Given this list of marker genes AQP10, AQP2, AQP6, AQP5, AQP12A, AQP1, AQP8, MIP, AQP9, AQP4, AQP7, AQP11, AQP3, here is a description of the gene set: Reactome Pathway: Passive transport by Aquaporins Aquaporins (AQP's) are six-pass transmembrane proteins that form channels in membranes. Each monomer contains a central channel formed in part by two asparagine-proline-alanine motifs (NPA boxes) that confer selectivity for water and/or solutes. The monomers assemble into tetramers. During passive transport by Aquaporins most aquaporins (i.e. AQP0/MIP, AQP1, AQP2, AQP3, AQP4, AQP5, AQP7, AQP8, AQP9, AQP10) transport water into and out of cells according to the osmotic gradient across the membrane. Four aquaporins (the aquaglyceroporins AQP3, AQP7, AQP9, AQP10) conduct glycerol, three aquaporins (AQP7, AQP9, AQP10) conduct urea, and one aquaporin (AQP6) conducts anions, especially nitrate. AQP8 also conducts ammonia in addition to water.<br>AQP11 and AQP12, classified as group III aquaporins, were identified as a result of the genome sequencing project and are characterized by having variations in the first NPA box when compared to more traditional aquaporins. Additionally, a conserved cysteine residue is present about 9 amino acids downstream from the second NPA box and this cysteine is considered indicative of group III aquaporins. Purified AQP11 incorporated into liposomes showed water transport. Knockout mice lacking AQP11 had fatal cyst formation in the proximal tubule of the kidney. Exogenously expressed AQP12 showed intracellular localization. AQP12 is expressed exclusively in pancreatic acinar cells.<br>Aquaporins are important in fluid and solute transport in various tissues. During Transport of glycerol from adipocytes to the liver by Aquaporins, glycerol generated by triglyceride hydrolysis is exported from adipocytes by AQP7 and is imported into liver cells via AQP9. AQP1 plays a role in forming cerebrospinal fluid and AQP1, AQP4, and AQP9 appear to be important in maintaining fluid balance in the brain. AQP0, AQP1, AQP3, AQP4, AQP8, AQP9, and AQP11 play roles in the physiology of the hepatobiliary tract.<br>In the kidney, water and solutes are passed out of the bloodstream and into the proximal tubule via the slit-like structure formed by nephrin in the glomerulus. Water is reabsorbed from the filtrate during its transit through the proximal tubule, the descending loop of Henle, the distal convoluted tubule, and the collecting duct. Aquaporin-1 (AQP1) in the proximal tubule and the descending thin limb of Henle is responsible for about 90% of reabsorption (as estimated from mouse knockouts of AQP1). AQP1 is located on both the apical and basolateral surface of epithelial cells and thus transports water through the epithelium and back into the bloodstream. In the collecting duct epithelial cells have AQP2 on their apical surfaces and AQP3 and AQP4 on their basolateral surfaces to transport water across the epithelium. Vasopressin regulates renal water homeostasis via Aquaporins by regulating the permeability of the epithelium through activation of a signaling cascade leading to the phosphorylation of AQP2 and its translocation from intracellular vesicles to the apical membrane of collecting duct cells.<br>Here, three views of aquaporin-mediated transport have been annotated: a generic view of transport mediated by the various families of aquaporins independent of tissue type (Passive transport by Aquaporins), a view of the role of specific aquaporins in maintenance of renal water balance (Vasopressin regulates renal water homeostasis via Aquaporins), and a view of the role of specific aquaporins in glycerol transport from adipocytes to the liver (Transport of glycerol from adipocytes to the liver by Aquaporins). studied in species Homo sapiens part of: Aquaporin-mediated transport